Given this list of marker genes MDM4, KCNJ3, RCAN3, MMP20, MED13, EXOC6B, RBM41, CHRM5, BRMS1L, C3AR1, ZDHHC5, GPRASP1, TMEM67, SNX21, GLRX2, CALHM1 (calcium homeostasis modulator 1), SP1, PCDH17, MAP2K1, ATXN7L3B, TPD52L3, USP38, VDAC2, RNF168, KIF26B, TICAM2, NCS1, NECAP1, COL4A4, BBS1, MFAP3L (NCBI Gene Id 9848), DIPK2A, CBX5, FAM229B, SPANXN1, BRWD1, CENPO, TMED7-TICAM2, RNFT1, LSM8, SMAP2, PPP1R9A, CTAGE1, SPRY2, LIF, KLF12, RAD50, CLVS2, CEP68 (NCBI Gene Id 23177), VSTM4, EOLA1, CCNG2, PLA2G3, HSPH1, BAGE2 (BAGE family member 2 (pseudogene)), CFAP91, FRMD4B, ZNF84, CNGB3, GABRA6, GAL3ST3, OTOGL, SPANXN5, GRIA1, ZNF280D, RND2, ENKUR, WDR18, VCL, BEST2, ADGRF1, here is a description of the gene set: from publication Chen Y, Wang X (PMID 31504780) Genes predicted to be targets of miRBase v22 microRNA hsa-miR-5196-3p in miRDB v6.0 with MirTarget v4 prediction scores > 80 (high confidence targets). Human Gene Set: MIR5196_3P studied in species Homo sapiens